The following is a description of a gene set: Elevated circulating creatine kinase concentration studied in species Homo sapiens An elevation of the level of the enzyme creatine kinase (also known as creatine phosphokinase (CK; EC 2.7.3.2) in the blood. CK levels can be elevated in a number of clinical disorders such as myocardial infarction, rhabdomyolysis, and muscular dystrophy. Human Gene Set: HP_ELEVATED_CIRCULATING_CREATINE_KINASE_CONCENTRATION, and this is the list of marker genes: SUOX, MB, MEGF10, POMT2, VPS13A, CHCHD10, PHKA1, CFL2, DAG1, TAMM41, MATR3, TMEM43, MT-TL1, BIN1, DMGDH, COX16, GNE (glucosamine (UDP-N-acetyl)-2-epimerase/N-acetylmannosamine kinase), NFS1, OBSCN, DHX16, TIA1, SVIL, PHKG1, GAA, TTN (titin), TRAPPC2L, CA2, GMPPB, QRSL1, HSPG2, MICU1, GYG1, DOK7, VCP, TMTC3, AHCY, SLC22A5, NARS2, DNAJB4, JAG2, AMPD3, DNM2, HADHA, PLA2G6, NEB, KLHL41, DPAGT1, CASQ1, DGUOK, COG6, TPM2, GTF2IRD2, MIEF2, NEFH, DMD, PDK3, GTF2I, LIMS2, PGAM2, TOR1AIP1, HADHB, DNAJC30, GOSR2, CAV3, TPM3, POMGNT2, MYL2, ACADVL, ACADM, RNASEH1, PHKA2, LARGE1, INPP5K, TWNK, ANXA11, PSMB9, OTUD5, COL12A1, TOP3A, CAPN3, OCRL, B3GALNT2, POLG2, CPT1A, ENO3, AP5Z1, SNUPN, HHAT, FLNC, NSUN2, CCDC115 (coiled-coil domain containing 115), MT-TL2, ALDOA, PIGY, BUD23, INF2, CNBP, MFN2, XK, ERGIC1, TMEM199, FKRP, ADSS1, KY, PITRM1 (NCBI Gene Id 22910), RTN2, DPM3, SGCD, ASAH1, FDX2, DNMT3B (DNA methyltransferase 3 beta), BAZ1B (NCBI Gene Id 9031), CRPPA, AR, CAVIN1, FLAD1, STIM1, SLC16A1, RILPL1, VPS37D, HNRNPA1, SLC25A4 (solute carrier family 25 member 4), GOLGA2, POGLUT1, PYROXD1, TBCK, COL6A1, CLIP2, PLEC, HMGCR, GTF2IRD1, ADK, CRYAB, LPIN1, SYNJ1, SGCB, HINT1, PEX6, PIK3R5, AMACR, TFG, LMNA, SGCG, C19orf12, TBCD, MT-TE, SGCA, VMA21, LMOD3, ATP5F1D, B4GALT1, MTMR14, POLG, SQOR, PET100, SMCHD1, PRUNE1, BVES, PNPLA2, PHKG2, TIMM22, SIL1, APTX, TRPV4, KCNE3, DUX4, GATB, COA7, MSTO1, COQ4 (coenzyme Q4), TMEM270, COL25A1, KBTBD13, GFPT1, SCN4A, B4GAT1, COG8, PIEZO2, GABRA3, PFKM, FILIP1 (filamin A interacting protein 1), SYNE1, LTBP4, TANGO2, MYH14, MT-CO1, TK2, NCF1, BAG3, COQ2, ITGA7, EMD, ALG2, DYSF, USB1, NEFL, LRP12, ITGB4, MYPN, COG7, SQSTM1, GGPS1, MPV17, POMGNT1, POMK, PLEKHG5, TNNT1, DNAJB6, UBA1, CPT2, YME1L1, ACTA1, MPZ, FKBP14 (NCBI Gene Id 55033), ISCU, SLC39A14, PABPN1, MYMK, DUX4L1, PLIN4, STX1A, POMT1, DNA2, LAMP2, PANK2, TSFM (Ts translation elongation factor, mitochondrial, NCBI Gene Id 10102), LIPE, BICD2, SPTAN1, ADRA2A, FRG1 (FSHD region gene 1), SLC25A42, HNRNPDL, COX20, TBL2, MYF6, HADH, ACTN2 (NCBI Gene Id 88), ELN, RYR1, AGL, LDB3, RRM1, VAC14, DPM2, MLIP, FKTN, ORAI1, ANO5, PGM1, VAPB, POPDC3, FKBP6, MGME1, ALG14, VRK1, DES, GIPC1, AMPD1, SYNE2, PYGM, COL9A3, AIFM1, RFC2, COL6A3, RRM2B, FHL1, MVK, COL4A1 (NCBI Gene Id 1282), EIF4H, TRMU, MPDU1, HNRNPA2B1, CHKB, NOTCH2NLC, SCYL2, C1QBP, TRIP4, TRIM32, COL6A2, SLC25A20, GATC, POLRMT, QRICH1, KCNA1, DPM1, LAMA2, LDHA, LIMK1, HEXB, MYH7, SETX, UQCRFS1, RBCK1, MT-CO3, SUCLA2, MT-TN, METTL27, DPYS, KCNJ18, EPG5, ACAD9, LAMA1, PLXNA1, TMEM165, MYOT (myotilin), TCAP, ISCA1, CACNA1S, FAM111B (NCBI Gene Id 374393), TRAPPC11 (NCBI Gene Id 60684, trafficking protein particle complex subunit 11), PHKB